The following is a description of a gene set: from publication Chen Y, Wang X (PMID 31504780) studied in species Homo sapiens Genes predicted to be targets of miRBase v22 microRNA hsa-miR-5000-3p in miRDB v6.0 with MirTarget v4 prediction scores > 80 (high confidence targets). Human Gene Set: MIR5000_3P, and this is the list of marker genes: WASF3, LMOD1, SSH1, BOD1, FMR1, UBXN7, SLC18B1, THRAP3, MTPN, AQP6, MMD2, TLCD4, CLCN3, PTPN1, PTP4A3, LINC02902, CNR1, CASP10, SPEG, RRAGD, LY75, NR2F1, BMP2K, DND1, CCN4, NALF1, FXYD3, HSPA4L, PAIP2B, LSM11, ETNK2, SPINK5, SKIDA1, TOMM6, SPCS2, STX1B, TMED4, UBE2N, LRRC59, CAP1, FCRL2, DOP1A, BORCS8, MAU2, H6PD, PACS2, SLIT2, PLAG1, RAB10, ARF3, HEG1, BOD1L2, RSKR, ARL15, WDFY3 (NCBI Gene Id 23001), HOXA5, MTMR4, PRPF38B, AAK1, DDX3X, RORB, ARL8A, TXNDC17, UPF3B, LCMT2, LINC02693, CCAR1, VPS35L, RALGAPA2, ARHGAP12, YTHDF3, DNAJA2, HSPA13, PRDM6, RAB9B, ZNF709, PAX6, NR2F2, CDK8, TMEM121B, DTNA (NCBI Gene Id 86552), ZNF423, FYN, FAM118B, ZFHX4, ACVR2B, DUSP3, ZIC3, PDCD6IP, MYCBP2, PCDH17, UBL3, SNAP25, URGCP-MRPS24, BCL11B, USP35, HMGCLL1, VAV3, MAP3K9, SLC39A7, XK, VPS29, ERGIC1, GFPT2, DKC1, CDKN2C (NCBI Gene Id 654235)